Given this list of marker genes NUP37, NUP85, NUP107, SEH1L, SEC13, NUP43, NUP133, NUP160, NUP98, AHCTF1, here is a description of the gene set: A subcomplex of the nuclear pore complex (NPC) that forms the outer rings of the core scaffold, a lattice-like structure that gives the NPC its shape and strength. In S. cerevisiae, the two outer rings each contain multiple copies of the following proteins: Nup133p, Nup120p, Nup145Cp, Nup85p, Nup84p, Seh1p, and Sec13p. In vertebrates, the two outer rings each contain multiple copies of the following proteins: Nup133, Nup160, Nup96, Nup75, Nup107, Seh1, Sec13, Nup43, Nup37, and ALADIN. Components are arranged in 8-fold symmetrical 'spokes' around the central transport channel. A single 'spoke', can be isolated and is sometimes referred to as the Nup84 complex (S. cerevisiae) or the Nup107-160 complex (vertebrates). Human Gene Set: GOCC_NUCLEAR_PORE_OUTER_RING studied in species Homo sapiens